The following is a description of a gene set: species: Homo sapiens from publication Holleman A, Cheok MH, den Boer ML, Yang W, Veerman AJ, Kazemier KM, Pei D, Cheng C, Pui CH, Relling MV, Janka-Schaub GE, Pieters R, Evans WE (PMID 15295046) Human Gene Set: HOLLEMAN_ASPARAGINASE_RESISTANCE_ALL_DN Childhood acute lymphoblastic leukemia (ALL) is curable with chemotherapy in approximately 80 percent of patients. However, the cause of treatment failure in the remaining 20 percent of patients is largely unknown. Genes distinguishing asparaginase resistant and sensitive ALL (B- and T-lineage ALL); here - genes down-regulated in the drug resistant samples., and this is the list of marker genes: CMC4, ARF6, RESF1, SUMO2, MED28, HSPA13, F8A1, MCUB, UBE2Z, ZNF318, CCNI, RCHY1, SNRPG, MAD2L1BP, DEDD, ZNHIT3, HNRNPF, RAB5C, ARRB2, PSME3, MARCKS, MRPL15, MAPK1IP1L, CCNG2 (NCBI Gene Id 901), DERL2, PPIA